Given this list of marker genes Gata4, E2f2, Ldb1, Nfe2l3, Nfil3, Hand1, Atf1-ps, Taf5l, Med15, Atf7, Creb1, Cebpz, Gtf2a1, Smad5, E2f4, Tcf3, Rfxap, Smad4, Rfxank, Nr1h3, Yap1, Vdr, Med22, Fosl1, Crebzf, Gtf2e1, Lef1, Maf, Mlxipl, Irf9, Nfe2l2, Hnrnpu, Taf6, Taf6l, Tbp, Ascl5, Tcf7l2, Ercc3, Pbx1, Bcl9l, Med4, Med10, Gtf2h1, Tcea1, Cebpg, Atf3 (activating transcription factor 3), S100a10, Nr5a2 (nuclear receptor subfamily 5, group A, member 2), Med21, Tcf4, Jdp2, Tcf12, Cebpe, Jund, Hmga1, Rfx5 (regulatory factor X, 5 (influences HLA class II expression)), Taf8, Stat2 (NCBI Gene Id 80602), Taf7, Hif1a, Atf6, Bmal2, Crebbp, Creb3, Ccnh, Taf12, Ncoa3, Bcl9, Taf13, Max, Stat5a, Junb, Ctnnb1, Supt3, Bach1, Med1, Thap11, Smad1, Med19, Nr1h5 (NCBI Gene Id 381463), Thrb, Taf4, E2f8 (E2F transcription factor 8), Taf9b (NCBI Gene Id 407786), Atf5, Hltf, Wwox, Pou2f1, Med27, Smad6, Hipk2, Ascl4, Tcf7, Gtf2a1l, Med30, Rb1, E2f5, Med20, Mafb, Ncoa1, Nfyb, Myb, Stat3 (NCBI Gene Id 68733), Taf10, Sfpq, Med16, Tcf15, E2f1, Mxd4, Hoxb9, Neurod1, Gtf2h5, Nfe2, Atxn7, Taf11, Atf4, Crem, Atf1, Taf9, Ascl2, Batf3, Rxra, Rara, Pou4f1, Ascl3, Dr1, Atxn7l3, Chd4, Cbfb, Med28, Batf, Crx, Med6, Med17, Pou2af1, Bmyc, Trp53, Med14, E2f3, Taf5, Usp22, E2f7, Taf7l, Cebpb, Stat6, Smad7, Smad3, Psmc5, Tfdp2, Mxi1, Batf2, Foxh1, Bach2, Med9, Anxa2, Nr1h4, Thra (thyroid hormone receptor alpha), Atf2, Rxrb, Taf3, Mlxip, Nfya, Nr5a1, Clock, Ing2, Gtf2b, Arnt, Trrap, Myc, Eny2, Cebpd (CCAAT/enhancer binding protein delta), Atf6b, Tcf7l1, Taf1, Mxd3, Med11, Lmo4, Ascl1, Gtf2h3 (NCBI Gene Id 75968), Runx3, Dbp, Hlf, Pasd1, Runx1, Gemin5, Gtf2h4, Gtf2f2, Npas2, Tle3, Med29 (mediator complex subunit 29), Pygo2, Med25, E2f6, Nono, Gtf2e2, Trim28, Rxrg, Stat1, Deaf1, Nfatc2, Myocd, Pparg, Jun (NCBI Gene Id 16476), Taf2, Cebpa, Fosl2, Tle4, Nkx2-5, Tead2, Gtf2f1, Med23, Mafg, Med31, Stat4 (NCBI Gene Id 20849), Med26, Ncoa2, Tada3, Maff, Med7, Tfdp1, Ddit3, Tbpl1, Med18, Nfyc, Bmal1, Mlx, Ercc2, Cdk7, Hnrnpab, Mnat1, Gtf2a2, Xbp1, Hyal2, Carm1, Adnp (NCBI Gene Id 98815), Smad9, Cbx3, Stat5b, Med24, Taf4b, Tle1, Fos, Tead1, Nr1h2, Med8, Kat2a, Gtf2h2, Drap1, Smad2, here is a description of the gene set: Mouse Gene Set: GOCC_RNA_POLYMERASE_II_TRANSCRIPTION_REGULATOR_COMPLEX species: Mus musculus A transcription factor complex that acts at a regulatory region of a gene transcribed by RNA polymerase II.